The following is a description of a gene set: from publication Kaji T, Ishige A, Hikida M, Taka J, Hijikata A, Kubo M, Nagashima T, Takahashi Y, Kurosaki T, Okada M, Ohara O, Rajewsky K, Takemori T (PMID 23027924) Genes down-regulated in follicular B lymphocytes: wildtype versus heterozygotic knockout of BCL6. species: Homo sapiens Bcl6 germline deletion causes a prominent inflammatory disease, owing to over-expression of Th2 cytokines, and affects the properties of B cells prior to immunization. Therefore we established the B cell-specific Bcl6 deletion mice and analyze the gene expression of naive B cells under physiological conditions. Human Gene Set: GSE28737_WT_VS_BCL6_HET_FOLLICULAR_BCELL_DN, and this is the list of marker genes: SIRPA, NUPR1, SAT1, UNCX, MMP23B, IL21R, SYK, ZC3H12A, PLA2G7, MAD2L1BP, RAD51, TESK2, STAT1, PTPN3, PRAM1, GBP6, NMI, FBXW7, ST8SIA6, NAALADL1, TXNRD1, ADCK1, ZNF467, KCNK6, SP4, CRNKL1, G2E3, RIPOR2, MAPDA, SASH3, MS4A8, ESR1, RAP2B, IL27RA, CA2, GPRC5B, PVT1, NOD1, APOF, AP4M1, SORL1, EHF, LXN, SPTSSA, UROD, CGAS, ST14, TPP1, ARR3, TMEM268, TENT5A, TFEC, COX18, MAPK11, VDR, BEND5, EPB41, STAP1, S100A6, C3orf80, TFAM, DDR1, LEO1, MSN, ACYP2, ADGRE1, CD68, FGL2, OGFRL1 (opioid growth factor receptor like 1), KRT23, ZFPL1, ESAM, GPR68, MTUS1, HARBI1, NDUFAF3, ITGAM, SLC25A30, RUNDC3B, F7, FAM229B, ADGRG5, CTSS, BHLHE40, IFIH1, KNOP1, CD4, TMEM241, SLC2A6, GBP7, SNHG8, NASP, TNFRSF1B, SPRING1, RAC2, EMILIN2, HADHA, MCCC1, OXCT2, GAB2, DBF4, ZBP1, CFP (NCBI Gene Id 5200), HOXD8, OPTN, SLC28A2, CD300LB, HOXA7, VRK1, NT5C3A (NCBI Gene Id 96002), CREB5, CCND1, ATP6V1C1, DENND11, PTGER3, SIRT4, AKAP13, PGAP1, BEND4, GHRH (growth hormone releasing hormone), CD5, GUCD1, EXOC6, ZBTB18, SLC15A3, ARHGAP9, PRMT2, RILPL2, TNFRSF13B, ASRGL1, GPR155 (G protein-coupled receptor 155), PAK1IP1, SELENOP, GCHFR, EED, PTGS2, DKK2, ACKR2, PPP1R12C, ANP32A, C9orf78, ATP8B4, AP3M2, CTSC, PTPRO, CD72, RDH12, ZNF503, CD300LF, REM1, HPRT1, RBM28, MRPL21, HSD17B4, CLEC5A, BOD1, CARMIL1, PLXND1, UBA7, UTP6, PRKCE, KCNIP3, RASA4, ST3GAL4, B3GNT2, PRPS1 (NCBI Gene Id 8254), ABHD14B (NCBI Gene Id 84836), TGM1, PAG1, RORA, ZNF131, ARL4C, MDH2, MKLN1, RNF114, RPP40, KRAS, LYSMD2, LRP8, DDB2, OR2S2, SPEF2, PSTPIP2, UCHL5, NSUN4, CIR1, TMEM192, MRE11, SHISA5, P2RY13, ACOD1, GLUL, UBL3, TEX29, FCGR2B, MAPK1IP1L, LPXN, UTP3, SHB (SH2 domain containing adaptor protein B), MTERF1